Given this list of marker genes CCDC57, DCTN1, MDM1, RTTN, CHMP1A, CETN3, TUBE1, GADD45A, ARHGEF10, PDE4DIP, CEP192, VPS4B, MCPH1, CHMP3, CEP72, HAUS4, BCL2L10, C2CD3, ALMS1, KIF3A, PKD2, CEP135, CEP85, CCNL1, PCM1, SDCCAG8, CDK1, C10orf90 (NCBI Gene Id 118611), FBXW5, RANBP1 (NCBI Gene Id 5902), PARD6B, SGO1, PLK2, CTNNB1 (NCBI Gene Id 1499), CHEK1, KAT2A, TMEM67, CEP295NL (NCBI Gene Id 100653515, CEP295 N-terminal like), MAP9, NDEL1, HAUS6, HAUS5, KIF11, BRCA2, CSAG1, KIAA0753, ARL2, MARK4, XPO1, CLASP2, BBS4 (NCBI Gene Id 585), CEP63, SLC16A1, HAUS8, TRIM37, CHORDC1 (cysteine and histidine rich domain containing 1), CHMP2A (NCBI Gene Id 27243), CCDC42, CHMP1B, OFD1, CEP68, HAUS3, HAUS1, CEP44, CDK11A, UXT, FBXW11, E2F4, CDK2, CETN2, KIAA1614, CROCC, PDCD6IP, PAFAH1B1, PPP1R12A, XRCC2, ATF5, CCDC78, RAB6C, HAUS7, NDE1, CHMP5, POC5, CLASP1, BRCA1, NUBP1, WDR90, CENATAC, PARD6G, TUBA1A, KIF25, PLK4, CNTLN, NEK2, CNTROB, FES (FES proto-oncogene, tyrosine kinase), POC1B, UBXN2B, SPICE1, CEP295, SAC3D1, NAT10, CDK5RAP2, NUP62, NSFL1C, NPM1, CCDC61, CDK11B, KIF3B, GCC2, UVRAG, SIRT1, NDC80, GEN1, POC1A, KIF15, CCDC15, PARD6A, ITGB1BP2, PCLAF, BRSK1, SASS6, NIN, CEP131, GOLGA2, RBM14, CCDC102B, CEP120, DEUP1, KAT2B, CHMP4C, AURKA, CHD3, CDC20B, ODF2, WDR62, HEPACAM2, CKAP5, PLK1, HAUS2, MCIDAS, BNIP2, XRCC3, CCNF, DNM2, SSX2IP, CHMP4B, ROCK2, PKHD1, STIL, FOXJ1, CENPJ, CCNL2, CEP250, CEP76, DZIP1, PPP1R35, CCP110, CHMP2B, CEP152, USP33, CETN1, here is a description of the gene set: studied in species Homo sapiens A process that is carried out at the cellular level which results in the assembly, arrangement of constituent parts, or disassembly of a microtubule organizing center, a structure from which microtubules grow. Human Gene Set: GOBP_MICROTUBULE_ORGANIZING_CENTER_ORGANIZATION